The following is a description of a gene set: species: Mus musculus Mouse Gene Set: GOBP_PROTEIN_LOCALIZATION_TO_MITOCHONDRION A process in which a protein is transported to, or maintained in, a location within the mitochondrion., and this is the list of marker genes: Pmpcb, Timm10, Tmem126a, Sirt4, Srebf1, Chchd4, Dnaja1, Dnajc15, Mapt, Bcs1l, Pdcd5, Mff, Bnip3l, Moap1, Tspo, Gsk3a, Timm22, Bag4, Marchf5, Timm50, Rnf186, Nol3, Siah3, Timm44, Hk1, Ndufa13, Bax, Bcap31, Timm17b, Dusp18, Ywhaz, Parl, Fbxo7, Pdcd5-ps, Fkbp8, Tomm22, Immp1l, Tomm5, Prkaa1, Sarm1, Cdkn2a, AU015836, Gdap1 (ganglioside-induced differentiation-associated-protein 1), Hspd1, Sh3glb1, Hspa1l, Adcy10, Timm8a1, Romo1, Timm13 (translocase of inner mitochondrial membrane 13), Lrrk2, Tomm20l, Dnm1l, Gfer (NCBI Gene Id 11692), Aifm1, Grpel1, Timm23, Pmpca, Agk, Tomm20, Tomm7, Eif2ak1 (NCBI Gene Id 15467), Mgarp, Maip1, Ptpn5, Tomm40, 4930550C14Rik, Hsp90aa1, Bag3, Isg15, Akt1, Bid, Oxa1l, Atp5if1, Fbxw7, Mavs, Fis1, Timm9, Timm17a, Ppp2r2b, Mterf4, Samm50, Mfn2 (mitofusin 2), Ap3b1, Dnajc19, Pam16, Ddit3, Mtch1, Tomm34, Mtch2, Timm21, Dusp21, Mipep, Tomm70a, Bag1, Timm29, Bbc3, Aip, Immp2l, Pmaip1, Grpel2, Dnlz, Cox18, Prkn, Tomm40l, Hk2, Rala, Pink1, Hspa4, Trmt10b